The following is a description of a gene set: studied in species Mus musculus The chemical reactions and pathways involving organophosphates, any phosphate-containing organic compound. Mouse Gene Set: GOBP_ORGANOPHOSPHATE_METABOLIC_PROCESS, and this is the list of marker genes: Guk1, Adora2b, mt-Nd5, Piga, Aspdh, Slc2a1, Nt5c2, Xylb, Inpp5k, Slc25a11, Nt5c1b (NCBI Gene Id 70881), Impa1, Slc25a25, Gpaa1, Dgkk, Adss2, Nudt8, Ndufv2, Ak2, Pisd, Mtmr2, Pgam2, Upp2, Slc30a5, Pygl (NCBI Gene Id 19308), Agpat4, Rrm2, Esrrb, Ak9, Adcy7, Mocs1, Galt, Plbd2, Ugp2, Parg, Avpr1b, Lclat1, Pnp2, Nt5c1a, Lyst, Mdh1b, Ndufb1 (NADH:ubiquinone oxidoreductase subunit B1), Mocs2, Atp5f1d, Acsl3, Dck (deoxycytidine kinase), Pigm, Fam3a, Cwh43, Prps1l3, Grk3, Impa2, Impdh2-ps, Uox, Dguok, Erbb4, Amdhd2, Mtmr10, Nudt14, Sult2b1, Ndufv1, Synj1, Tkfc, Acss2, Dpys, Sacm1l, Mlst8, Mboat2, Ndufb8, Mpc1, Pgls, Fbp1, Acot2, Ampd1, Ndufb10, Bpgm, Papss1, Sult2a4, Acacb, Entpd5, Pank1 (NCBI Gene Id 78262), Gata6, Smpd4, Vnn1, Adcy3 (adenylate cyclase 3), Gmps (guanine monophosphate synthetase), Plscr3, Pla2g4f, Ldhb, Hspa1b, Slc25a18, Mtmr9, Ola1, Gnpda1, Guca1b, Slc4a1, Dlat, Bad, Enpp5, Glyat, Cd244a, Hsd17b4, Pfkfb4, Sdhc, Plcb2 (phospholipase C, beta 2), Isyna1 (NCBI Gene Id 71780), Nupr1, Plpp5, Bscl2, Ier3, Arnt, Pfkfb2, Aldoc, Nus1, Kmo, Chpt1 (NCBI Gene Id 212862), Nmrk2, Nudt16, Atp1b1, Acot5, Inpp5e, Nmrk1, Ptdss1 (NCBI Gene Id 19210), Pla2g10, Gpat4, Abca8b, Prdx6b, Plpp4, Fhit, Uckl1, Pde8b, Oxct2a, Ugdh, Sptlc1, Itpk1, Gpld1, Atic, Ndufa6, Rptor, Bcl2l1, Park7, Inpp4b, Hdac4, Nt5c3b, Gk2 (glycerol kinase 2), Acot7 (acyl-CoA thioesterase 7), Opa1, Mas1, Dcxr, Nppb, Pigx, Plppr4, Slc25a16, Hnf4a, Kat2b, Nudt13 (nudix hydrolase 13), Dip2a, Enpp2, Pde7a, mt-Nd3, Abhd3, Plpp6, Atp6v1b2, Gcdh, Ldlr, Upb1, Ormdl3, Xdh, Zbtb7a, Fuom, Lpcat1, Sord, Htr2c, Nadsyn1, Art2b, Gtpbp1 (NCBI Gene Id 97981, GTP binding protein 1), G6pc1, Entpd3, Mfsd2a, Nadk, Tmem150a, Insr, Dld, Ins2, Dgka, Il4, Hmgcl, Pnpo, Hk2, Slc52a3, Atp6v1a, Gapdhs, Mtmr12, Mmut, Prdx6, Uck1, Pde5a, Ak7, Pgap1, Kars1, Prkcd, Slc2a6, Pla2g4c, Acsm2, Lpcat3, Taldo1, Ddit4, Sdhd, Naprt, Prkg1, Sult2a6, Trp53, Pi4k2b, Fdft1, Gpat2, Dtymk, Aldh1l2, Pla2g7, Pla2g5, Ndufv3, Dgkz, Rrm1, Ak1, Hycc1, Mvk, Alox8, Rhoa, Oga, Pdhb, Slc35a1 (NCBI Gene Id 99967), Lrat, Rfk, Ndufs4 (NADH:ubiquinone oxidoreductase core subunit S4), Tafazzin, Shmt1, Pmm1, Agap2, Nme7, Nr1h4, Plcd4, Bpnt1 (NCBI Gene Id 23827), Abcd1, Pde9a, Ep300, Far2, Actn3 (NCBI Gene Id 11474), Mccc2 (NCBI Gene Id 78038), Pign, Sult1c1, Ddhd1, Atp6-ps, Rab38, Hsd11b1, P2ry1, Got1, Mpc2, Tk1 (NCBI Gene Id 21877), Dhfr, Ido2, Pdhx, Ak3, Pi4kb, Adsl, Spata18, Napepld, Acadsb, Mtmr4, Pcyt1b, Pth2, Myh9, Pmm2, Nkx2-1, Dgkq, Trem2, Pitpnc1, Abhd16a, Plppr1, Pgd, Prkn, Aox1, Atp6v1b1, Pik3r1, Plaat5 (NCBI Gene Id 73514), mt-Atp8, Dpm3, Nudt12, Ormdl1 (NCBI Gene Id 252836), Flvcr1, mt-Nd1, Gnb3, Gfus, Nans, App, Pals1, Cbfa2t3, Dgkh, Lcat, Gimap7, Smpdl3a, Pigyl, Tspo, Alpi, Naxd, Ndufa7, mt-Atp6 (NCBI Gene Id 98563), Tnxb, Hk1, Dolk, Uprt, Ins1, Atp5mf, Nnt, Sgms2, Abhd16b, Gmppa, Ces1d, Pgm1 (phosphoglucomutase 1), Pla2g2a, Abca2, Slc4a7, Plb1, Efl1, Dbi (diazepam binding inhibitor), Them5, Acot10, Acot1, Uvrag, Eno1, Fignl1, Lacc1 (NCBI Gene Id 210808), Rab23, Pklr, Oasl2, Arf1, Igf1, Sptlc2, Cds2, Inpp5d, Fkrp, Nudt10, Nt5m, Nfe2l1, B3galnt2, Vac14, Sphk2, Nudt5, Pla2g2d, Sgms1, Clpx, Mtmr6, Adal (NCBI Gene Id 75894), Nt5c3, Galm, Nadk2 (NCBI Gene Id 71201), Ndufc2, Ctns, Adgrf5, Gmds, Enpp3, Acat1, Dmac2l, Ogt, Entpd2, Slc52a2, Pank4 (NCBI Gene Id 97197), Entpd1, Mmaa, Pnpla6, Parp14, Fabp5, Ppp2ca, Gnpnat1, Pgp, Ncf1, Prkaa1, Hprt1, Pals2, Plpp2, Far1, Acss1, Cmpk1 (NCBI Gene Id 66588), Chka, Nme2, Pik3c2b, Pip5k1a, Shpk, Pip4p2, Etnppl, Hmgcs1, Prps1, Dpm1, Vcp, Pdgfb, Guca1a, Slc19a3, Tigar, Smpd5, Ndufa12, Rd3, Abca8a, Acp6, Serac1, Pla2g2f, Atp7a, Tbpl1, Pck1 (phosphoenolpyruvate carboxykinase 1, cytosolic), Uap1, Adk, B4galnt2, Ndufa2, Aco1, Aspg, Col6a1, Oc90, Hspa8, Pik3r4, Uqcc3, Ndufb5, Map2k1, Pip4p1, Mthfd2l, Plppr5, Pfkfb3, Pigo, Ctps2, Gart, Pon1, Pgap3, Qprt, Elovl1, Acp3, Pgap4, Ak5, Naxe, Ndufs8, Il3, Ggps1, mt-Nd2, Cdipt, Ak4, Phb2, Slc29a1, Slc27a3, Adpgk, Atp5mc2, Acot4, Src, Gapdhrt2, G6pc2 (NCBI Gene Id 14378), Gpam, Prps2, Ndufa13, Cfh, Atp5mc1, Sh3yl1, Itpa, Ak6, Dhodh, Plcb3, Atm, Bpnt2, Slc25a42, Atg14, G6pd2, Ak8 (adenylate kinase 8), Dnph1, Dpm2, Acot3, Stat3, Plcl2, Hk3, Pdha2, Macroh2a1, Khk, Entpd7, Rbks, Mthfd1, Ip6k1 (NCBI Gene Id 67601), Nudt15, Pde8a, Mtm1, Mgat1, Inpp1, Gmppb, Slc1a3, Adcy10, Art2a, Pkm, Fpgt, Pik3c2a, Cds1, Pigs, Itpkc, Phex, Pik3cd, Pid1, Atpsckmt, Thtpa, Prpsap1, Slc25a51, Pla2g3, Dgkg, Pde10a, Nppc, Dgke, Acsl4, Pou1f1, Tmsb4x, Pdk1, Upp1, Fcsk, Ppip5k2, Pnpla7, Sult2a2, Gda, Extl2, Aldoart2, Acot9, Fitm1 (NCBI Gene Id 68680), mt-Nd6, Impdh1, Gk5, Pank2, Hycc2, Idh2, Sirt6, Gnpda2 (NCBI Gene Id 71118), Pdk4, Hexb, Adcy4, Pnpla8, Serinc1 (NCBI Gene Id 80452), Ndufb7, Becn1, Nanp, Pik3cb, Abhd4, Got2, Uxs1, Mlycd, Pde4c, Gper1, Dgat1, Gpd1, Pigg, Rhoq, Parp1, Acnat1, Ndufb9, Snca, Hmgcs2, Oas1a, Pdgfa, Prkag1, Dlst, Pde4a, Ran, Suclg2, Atp5pb, Mlx, Dgki, Ldhc, Pla2g1b, Selenon (selenoprotein N), Ampd2, Pla2g15, Nudt19, Agpat5, Myh3, Ldha (NCBI Gene Id 16828), Eno3, Alpl, Acot11, Nmnat3, Gucy2f, H6pd, Cda, Pfkm, Fis1, P2ry6, Plek, Idi2, Gfpt2, Pfas, Plaat1, Tamm41, Entpd4, Fitm2, Rpe, Nudt7, Elovl7, Nudt18, Sult2a8, Plbd1, Nfs1, Nme4, Acsl5, Ndufb4, Agpat2, Pla2g6, Ndufs7, Plscr1 (NCBI Gene Id 54533, phospholipid scramblase 1), Sult1b1, Pla2g4b (NCBI Gene Id 545452), Epha2 (NCBI Gene Id 13836), Mtch2, Lpcat2b, Umps, Bckdk, Atp5f1a, Slc37a2, Lpin1, Cmah, Pipox, Pigp, Samhd1, Pigh, Gapdh, Nt5e, Dgkb, Sh3glb1, Pyurf, Pgam1, Mppe1, Cs, Ndufs2, Myh6, Adcy8, Ipmk, Htr2a, Mtor, Ckmt2, Kynu, Dnm1l, Trim63, Cept1, Atp5f1c, Angptl3, Ip6k2, Mpi, Tgds, Gmpr2, Ndufs3, Pnpla3, Pla2g4d, Idi1, Scp2, Tpi1, Apoc2l, Atg5lrt, Osbp, Abhd12b, Pip4k2c, Pld1, Smpd1, Plppr3, Apoa4, Ptprq, Ldhd, Samd8, Hif1a, Pdk3, Acsl1, Adcy1, Foxk2, Haao, Pikfyve, Pdgfrb, Pigz, Adcyap1r1, Ndufs5, Smpd2, Efr3b, Gars1, Dpyd, Ada, Itpkb, Ntsr1, Aass, Atp2b2, Acot12, Acsm3, Capn2, Pip4k2a, Alox15, Tmem38b, Smpd3, Fdps, mt-Nd4l, Pik3cg, Pgs1, Gck, Pank3, G6pdx, Ndufa9, Cln3, Gucy2c, Gnai3, mt-Nd4, Nampt, Bloc1s6, Lpcat2, Pfkfb1, Naaa, Fabp3, Me2, Stoml2, Dgkd, Abca3, Nme6, Pigq, Scarb1, Nudt4, Gk, Nudt3, Aldob, Lpgat1, Selenoi, Gfpt1, Slc25a22, Serinc5, Acsl6, Plch2, Sult2a5, Urad, Pemt, Pla2g2c, Nos3, Myc, Gpcpd1, Tkt, Smg1, Ip6k3, Pip5k1c, Enpp7, Pigw, Cyb5r4 (NCBI Gene Id 97535), Gapdhrt, Pip4k2b, Sult2a1, Cox11, Nudt2, Pla2g4a, Inppl1, Dpagt1, Inpp5a, Mvd, Inpp5j, Acot6, Mboat7, Afmid, Mfsd8, Pla2g4e, Cyp2w1, Mocs3, Coasy, Ndufs6, Pld2, Cacnb4, Aadat, Nme1, Sucla2, Mtmr7, Apoa1, Plch1, Dhdds, Prxl2c, Pik3c2g, Dgat2, Pla2g2e, Sgpp1, Nnmt, Suclg1, Apoc1, Mfn1, Ndufb11 (NADH:ubiquinone oxidoreductase subunit B11), Gykl1, Cmas (NCBI Gene Id 12764), Gpi1, Mboat1, Pfkp, Sik2, Slc25a13, Nt5c, Prkaa2 (NCBI Gene Id 66516), Rora, Ndufs1, Dhrs7b, Galk1, Gucy1b1, Pgk2, Abcc6, Ndufa11, Entpd4b, Plpp1, Pigv, Myog, Tdo2, Mdh1, Pten, Ocrl, Ttc7, Plcl1, Cln8, Plcb1, Prkag2, Jmjd8, Ndufa1, Urah, Pde4d, Slc27a1 (solute carrier family 27 (fatty acid transporter), member 1), Ndufa8 (NCBI Gene Id 99357), Plaat3, Ppcdc, Nudt17, Pnliprp2, Abcc9, Pde7b, Npr2, Flcn, Git1, Prkag3, Tpk1, Ttc7b, Ndufab1 (NADH:ubiquinone oxidoreductase subunit AB1, NCBI Gene Id 72270), Plcg2, Inpp5b, Pigk, Pth, Cad, Vapa, Atp5pd, Cps1, Elovl5, Eno1b, Lpcat4, Rrm2b, Ckb, Elovl6, Zbtb20, Apoa2, Nme3 (NME/NM23 nucleoside diphosphate kinase 3), Csl, Enpp1, Sdha, Paics, Trex1, P2rx7, Atp1a2, Mcee, Mlxipl, Nudt9, Slc35c1, Pip5kl1, Atp5po, Gpat3, Cmpk2, Impdh2, Sult2a3, Pcx, Gucy2e, Itpka, Sult1e1, Fmo2, Tyms, Mocos, Uap1l1, Ndufa5, Antkmt, Foxk1, Pdxp, Atp5mg, Shmt2, Sdhb, Mapk1, Dctd, Gucy2d, Nmnat1, Psen1, Pigb, Pde2a, Nudt11, Ncor1, Pfkl, Pik3c3, Plcg1, Nmnat2, Adcy5, Pcyt2, Pcsk9, Ucp2, Nr1h2, Ndufb3, Synj2, Ptdss2, Baat, Acaca, Plcd1, Acly, Uggt1, Ido1, Ndufa3, Dctpp1, Plpp3, Pik3ca, Elovl4, Flad1, Hnf1a, Hmgcr, Pgm3, Cnp, Inpp5f (inositol polyphosphate-5-phosphatase F), Ptpmt1, Tgfb1, Fasn, Gucy2g, Ppargc1a, Pigt, Pth1r, Prkaca, Mtmr1, Fut8, Cryl1, Lipa, Pgk1, Inpp4a, Acot8 (NCBI Gene Id 170789), Serinc2, Pi4ka, Atp5mc3, Ogdh, Letmd1, Ndufa10, Hint1, Hrh3, Sult2a7, Pudp, Pigl, Abhd8, Pgap2, Aldoa, Fbp2, Atp5if1, Ndufc1, G6pc3, Adcy2, Etnk1, Ppard, Ampd3, Tnfaip8l3, Pdk2, Fig4, Idh1 (NCBI Gene Id 98427), Lhcgr, Hdhd5, Abhd12, Ckm, Gdpd3, Pmvk, Pnp, Myh8 (NCBI Gene Id 544790), Eif6, Uck2, Nme5, Gphn, Arl2, Ckmt1, Agpat3, Atp5me (NCBI Gene Id 70034), Npr1, Crls1, Adcy6, Slc25a12, Pde1a, Ajuba, Ctps1, Agpat1, Ppara, Atp5f1b, Abhd5, Elovl3, Plppr2, Crot, Gde1, Acsm4, Plce1, Oxsm (3-oxoacyl-ACP synthase, mitochondrial), Chrm5, Slc4a4, Lrrk2, Rnaseh2b, Rpia, Vdac1, Pdxk, Eno4, Prps1l1, Ncf2, Papss2 (3'-phosphoadenosine 5'-phosphosulfate synthase 2), Dera, Ppat, Me1, Tk2, Gdpd1, Slc25a10, Pdha1, Adss1, Ppip5k1, Pik3r5, Pip5k1b, Pla2g12b, Nr1h3, Prpsap2, Aldoart1, Gne, Noct, Nppa, Pla2g12a, Proca1 (protein interacting with cyclin A1), Pcyt1a, Ptafr, Pigc, Acaa2, Dut, Acsm1, Abhd6, Mecp2, Aldh1l1, Pigf, Dnajc19, Pi4k2a, Slc19a2, Akr1a1, Eno2 (NCBI Gene Id 52283), Atp5f1e, Acsm5, Acnat2 (NCBI Gene Id 209186), Galr2, Slc25a19, Hkdc1, Mdh2, Dcakd, Htr2b, Serinc4, Smpdl3b, Myh7, Sarm1, Hadha, Gpd1l, Ippk, Ndufb2, Mtmr3, Ppcs, Mtmr11, Ehhadh (NCBI Gene Id 74147), Gpd2, Bend3, Entpd8, Gale, Chp1, Bcl2l13, Tymp, Aprt, Ndufb6, Apoc2, Ifng, Atp5pf, Chkb, Csgalnact1, Cant1, Dhtkd1, Gucy1a1, Dnajc30, Pigu, Etnk2, Gnpat, Plcb4, Lipc, Gmpr, Fgf7, Adcy9, Uchl1